The following is a description of a gene set: studied in species Mus musculus Genes predicted to be targets of miRBase v22 microRNA mmu_miR_484 in miRDB v6.0 with MirTarget v4 prediction scores > 80 (high confidence targets). from publication Chen Y, Wang X (PMID 31504780) Mouse Gene Set: MIR_484, and this is the list of marker genes: Ptpre, Hook2, Hivep2, Gm14295, Snx17, Exd2, Nxph2, Hnf1a, Zswim5, Nuf2, Mmrn1, Pde6g, Acvr1b, Serpina3b, Lrrc3, Smcr8, Mycbp2, Map4k2, Tspan17, Clock, Kcnj5, Dgkz, Mprip, Mapkapk2 (MAP kinase-activated protein kinase 2), Cldn18, Adgrl4, Prrt2, Fam168a, Tgfbr3, Zmiz1, Tob2, Maml2, Retreg1, Ptger4, Tmed8 (NCBI Gene Id 76230), Med8, Magi1, Ipo11, Ppl, Tsga10, Rbm27, Map2, Slc4a4, Ripk3, Sirt2, Mgat5, Zswim6, Tnrc6c, Trps1, Cyb5d2, Snn, Tnr, Stard13, Kmt2a, Pde1c, Anapc15, Hoxa5, Tbc1d24, Strn, Pgbd5, Gabpa, Fbxl2, Add2, Rnf14, Plcxd2, Kcnt2, Klkb1, Pla2g10, Rab1b, Dlst, Negr1, Nol6, Amer3, Dpysl2, A2ml1, Disp2, Kcnma1, Nfe2l1, Tor3a